The following is a description of a gene set: Human Gene Set: GSE5455_HEALTHY_VS_TUMOR_BEARING_MOUSE_SPLEEN_MONOCYTE_DN Active suppression of tumor-specific T lymphocytes can limit the immune-surveillance and immunotherapy efficacy. While tumor-recruited CD11b+ myeloid cells are known mediators of tumor-associated immune dysfunction, the true nature of these suppressive cells and the fine biochemical pathways governing their immunosuppressive activity remain elusive. Here we describe a population of circulating CD11b+/IL-4Rα+, inflammatory-type monocytes that is elicited by growing tumors and activated by IFN-γ released from T lymphocytes. CD11b+/IL-4Rα+ cells produce IL-13 and IFN-γ and integrate the downstream signals of these cytokines to trigger the molecular pathways suppressing antigen-activated CD8+ T lymphocytes. Analogous immunosuppressive circuits are active in CD11b+ cells present within the tumor microenvironment. These suppressor cells challenge the current idea that tumor-conditioned immunosuppressive monocytes/macrophages are alternatively activated. Moreover, our data show how the inflammatory response elicited by tumors has detrimental effects on the adaptive immune system and suggest novel approaches for the treatment of tumorinduced immune dysfunctions. studied in species Homo sapiens Genes down-regulated in ITGAM+ cells from spleen: healthy versus tumor bearing mice. from publication Gallina G, Dolcetti L, Serafini P, De Santo C, Marigo I, Colombo MP, Basso G, Brombacher F, Borrello I, Zanovello P, Bicciato S, Bronte V (PMID 17016559), and this is the list of marker genes: SPON1, CDR2, AATF, L1CAM, DOCK10, CISH, AXL, IQGAP2, SYT8, IFITM2 (NCBI Gene Id 10581), PDE8A, H3C14, ADGRG3, SLC2A3, PIK3R1, SOAT2, ST8SIA6, HID1, GFOD2, LFNG, ROM1, NOD1, CAPG, ATP1B3, C21orf91, CD226, KLRD1, PIK3R5, COLGALT1, TAFA3, ITSN1, KLK8, IDH2, IMPDH1, ZFC3H1, IRF4, DENND5A, OSM, CPM, CRYBG3, SLC52A3, ANGPTL6, TIGAR, TBXA2R, IMP3, SUOX, SMAD7, CCR5, OTULINL, ITGB3, TMPRSS13, STK38, LBP, SERPINI1, C15orf48, RRAD, PGLYRP2, B4GALNT1, ME2, DPY19L1, QTRT1, BEND5, USP22, STX1A, DUSP22, ITGA6, NIN, P2RY14, DAPL1, CKLF, RAP1GAP2, HAAO, ENTPD1, ATP10A, ADPGK, GZMB, KLF16, TDRP, GGT1, NKTR, SIDT1, ORAI2, APPBP2, SIKE1, KCNJ16, IZUMO4, EMP1, SNHG6, SLC17A9, SELPLG, ZC3H8, LRRC8A, BCL2L11, USP48, COPG1, LAIR1 (leukocyte associated immunoglobulin like receptor 1), PRKD3, RCBTB2, KLRK1, MRPS5, RASGRP2, SYBU, TGIF1, S100A4, GLIPR2, PIK3IP1, S1PR4, SYP, PRPS1 (NCBI Gene Id 8254), GPR18, TENT5A, NDRG1, FRMD6, EXOSC1, NHSL2, ACSBG1, CRYBG1, UST, SLC20A1, TAGLN2, IL2RA, MATN2, PPP3CA, SARAF, RPS5, ATP8B4, NCKAP1, NEB, ADCY3, EEIG2, FRY, STMN2, PPM1J, TMEM64, FOSL2, MED7, IL18RAP, BST2, KLF13, ITGAE, SYTL2, GAB3, RPL14, QPCT, ADAM8, GALNT10, ADCY6, PCSK1, NPC2, FCGRT, FAM110B, PHYHD1, GSTO1, MTSS1, IKZF4, LMNA, CORO2A, LYPD6B, LDB1, DNAJC15, SORL1, SPICE1, SOCS2, CA11, IGFBP4, ITGA4, TESK1, TACC2, MEX3A, ACTN2, ADGRE5, L3MBTL3, ARMC7, UBXN11, CTSW, GPR34, BRI3, RRAS2, CSRNP2, HLA-DMA, GK5, ACVRL1, UNC5CL, LRRC75B (leucine rich repeat containing 75B), PAQR8, RCN3, TKTL1, CRIP1, TMEM41A, STK38L, INF2, CDC42EP4, ITGB1 (integrin subunit beta 1), TTL, PDK1, TBX21, ARL4C, RASA3 (NCBI Gene Id 22821), TNFSF4